Given this list of marker genes Dcc, Cdc42, Trio, Dock1, Prkcq, Dscam, Ptk2, Unc5a, Dscaml1, Rac1, Ntn4, Ezr, Fyn, Nck1, Src, here is a description of the gene set: Netrin-1 signaling Mouse Gene Set: REACTOME_NETRIN_1_SIGNALING species: Mus musculus